The following is a description of a gene set: The chemical reactions and pathways involving hepoxilins, a class of bioactive icosanoids with roles in the regulation of cell physiology. species: Homo sapiens Human Gene Set: GOBP_HEPOXILIN_METABOLIC_PROCESS, and this is the list of marker genes: ALOX15B, GSTM1, ALOX12B, GSTM2, ALOX15, ALOXE3, GSTP1, ALOX12